The following is a description of a gene set: Catalysis of the reaction: leukotriene C(4) = glutathione + leukotriene A(4). studied in species Homo sapiens Human Gene Set: GOMF_LEUKOTRIENE_C4_SYNTHASE_ACTIVITY, and this is the list of marker genes: LTC4S, GSTM4, MGST2, ALOX5AP, MGST3